Given this list of marker genes KAT2B (lysine acetyltransferase 2B), RCC2, AURKB, KAT5, CDCA8, BECN1, SIRT2 (NCBI Gene Id 22933), BIRC5, CCNB1, INCENP, HNRNPU, here is a description of the gene set: studied in species Homo sapiens Any process that activates or increases the frequency, rate or extent of the attachment of spindle microtubules to the kinetochore. Human Gene Set: GOBP_POSITIVE_REGULATION_OF_ATTACHMENT_OF_SPINDLE_MICROTUBULES_TO_KINETOCHORE